Given this list of marker genes Bmi1, Nup37, Seh1l, Ranbp2, Nup93, Ube2i, Rae1, Phc2, Scmh1, Phc3, Nup35, Ring1, Pcgf2, Nup188, Nup58 (nucleoporin 58), Sumo2, Nup160, Nup133, Nup210, Nup43, Tpr, Nup214, Nop58, Cbx4, Sumo1 (small ubiquitin-like modifier 1), Cbx2 (chromobox 2), Nup153, Rnf2, Nup88, Nup205, Hnrnpc, Pom121, Nup42, Aaas, Phc1, Cbx8, Sec13, Nup62, Ndc1, Nup98, Nup107, Nup155, Nup85, Nup50 (NCBI Gene Id 69508), Nup54 (nucleoporin 54), Hnrnpk, here is a description of the gene set: studied in species Mus musculus SUMOylation of RNA binding proteins Mouse Gene Set: REACTOME_SUMOYLATION_OF_RNA_BINDING_PROTEINS